The following is a description of a gene set: Mouse Gene Set: TABULA_MURIS_SENIS_MARROW_MONOCYTE_AGEING from publication Tabula Muris Consortium (PMID 32669714) studied in species Mus musculus, and this is the list of marker genes: Tmem176a, Ldha, H2-Aa, Jchain, Pdia3, Cd24a, Mdh2, S100a9, Rsrp1, Eif3i, Rps19, Lcn2, Wfdc17, Tuba1b, Ifitm2, Gngt2, Rpl36a, Sirpb1c, Abi3, Camp, Apoe, Gas5, Cfh, Prelid1, Tubb5, AW112010, Rpl35, Ifi30 (NCBI Gene Id 65972), Retnlg, H2-DMb1, H2-Ab1, Elane, S100a8, Ctsd, Rpl3, Rps18, Rbm3, Ssr4, Wfdc21, Ltf, Tmem176b, H2-Eb1, Rplp0, App (amyloid beta precursor protein), Apoc2, Rps26, Rpl14, Gapdh, Rps28, Prtn3, Ap3s1, Ngp, Rpl41, Cd74